Given this list of marker genes HBA1, ELN (elastin), KRT10 (NCBI Gene Id 3858), RPS17, KRTDAP, FABP4, HTRA1, UQCR10, DNAJA1, SPARC, CEBPB, CCN3, BST2, HSPH1, CAV1, ACTA1, BGN, PTOV1, IGFBP7, FBN1, CD83, EGF, HBB, ITM2A, APOC3, HLA-DQB1, ID4, SLC12A1, ACTG2, DCN, SAT1, COL1A1, FABP1 (fatty acid binding protein 1), FHL1, CST3, CTSV, ID3, MTCH1, OGN, PPIC, SERF2, BTG1, CCL21, OAF, PLTP, ZFP36, TPPP3, JUND, CHD2, LUM, MFAP2, SELENOW, PCOLCE, RTN4, LOX, TAGLN, IFI27 (interferon alpha inducible protein 27), YBX1, COL18A1, CRIP1, ITGB5, LY6D, RPS28, UMOD, PAM, COL4A1, FN1, DPT, MGST3, NDUFA4L2, RND3, MYH11, HLA-DRA, MT-ATP6, SPTSSA, C1QB, FSTL1, MYL9, GSN, HSPB1, CNN1, DAPL1, MFAP5, PLAC9 (placenta associated 9), MRC1, TUBA1A, IGFBP6, PFN1, HSP90AA1, PTMS, JUN, PRDX1, RPL38, FAM25A, CSF1R, HLA-DQA1 (NCBI Gene Id 7946), KLF4, APOC1, COL15A1, HEXA, ALB, CCDC80, EIF4A1, HSPA8, GAS6, TMEM176B, TIMP2, SERPINH1, HES1, ATP5ME, DYNLL1, PPP1R14A, KRT1, COL6A2, DNAJB1, FCGRT, LYVE1, LGALS1, FLNA, LAMP1, TGFBI, RPGR (retinitis pigmentosa GTPase regulator), F13A1, RPL37, YWHAH, DUSP1, TPM2, SOSTDC1, LGALS7, FOS, CAVIN3, GADD45G, HSPA1A, ATF3, COL1A2, CCL24, RPL39, CPZ, RBP7, POSTN, RPS21, SERPINF1, TPM1, FAM111A, CSRP1, FRZB, LTC4S, PRSS23, MAP1LC3A, MT-ND1, DES, WFDC1, IGFBP3, KRT14, EGR1, CITED2, DMPK, COL3A1, DSTN, RPS29, here is a description of the gene set: Human Gene Set: MA_RAT_AGING_DN from publication Ma S, Sun S, Geng L, Song M, Wang W, Ye Y, Ji Q, Zou Z, Wang S, He X, Li W, Esteban CR, Long X, Guo G, Chan P, Zhou Q, Belmonte JCI, Zhang W, Qu J, Liu GH (PMID 32109414) studied in species Rattus norvegicus Aging causes a functional decline in tissues throughout the body that may be delayed by caloric restriction (CR). However, the cellular profiles and signatures of aging, as well as those ameliorated by CR, remain unclear. Here, we built comprehensive single-cell and single-nucleus transcriptomic atlases across various rat tissues undergoing aging and CR. CR attenuated aging-related changes in cell type composition, gene expression, and core transcriptional regulatory networks. Immune cells were increased during aging, and CR favorably reversed the aging-disturbed immune ecosystem. Computational prediction revealed that the abnormal cell-cell communication patterns observed during aging, including the excessive proinflammatory ligand-receptor interplay, were reversed by CR. Our work provides multi-tissue single-cell transcriptional landscapes associated with aging and CR in a mammal, enhances our understanding of the robustness of CR as a geroprotective intervention, and uncovers how metabolic intervention can act upon the immune system to modify the process of aging. Genes down-regulated across multiple cell types from nine tissues during rat aging.